The following is a description of a gene set: studied in species Mus musculus Mouse Gene Set: GOBP_SPHINGOID_METABOLIC_PROCESS The chemical reactions and pathways involving sphingoids, any of a class of compounds comprising sphinganine and its homologues and stereoisomers, and derivatives of these compounds., and this is the list of marker genes: Plpp3, Asah1, Acer2, Naaa, Sptssa, Kdsr, Acer3, Asah2, Gba1, Degs2, Acer1, Agk, Sptlc1, Sgpp1, Sptlc3, Sptlc2, Sptssb, Abca2, Sphk2, Plpp2, Sphk1, Sgpp2, Plpp1